Given this list of marker genes IL6, CNTF, CLU, ITGB4, SLC25A46, TNF, S100A8, GSTP1, MIOS, TREM2, EIF2B3, FPR2, GFAP, PHGDH, SOX10, B4GALT6, CCDC39, KRAS, SHH, ROR1, PRX, CDK6, ZNF488, ERBB2, TPPP, SIRT2, ZEB2, MAL, PLP1, AGER (NCBI Gene Id 177), RAF1, PRDM8, LRP1, FA2H, MAP2K1, PTEN, NAGLU, CERS6, IFNGR1, DICER1, ARHGEF10, MAPK3, SOX4, ILK, ASCL1, AKT1, MED12, VIM, ERBB3, MIR142, POU3F1, CNTN1, MAPT, EIF2B1, CNTN2, EIF2B5, HES5, CD9, APP (NCBI Gene Id 351), C5AR1, ANO1, WASF3, ADORA2A (NCBI Gene Id 135), ABCA2, IFNG, HRAS, PPP3R1, ID4, CNTNAP1, KCNJ10 (NCBI Gene Id 3766), PSEN1, MYOC, NRROS, IL1B, COL6A1, MAP2K2, SOX11, GRB2, MIR181C, NF1, POU3F2, ID2, TGFB1, NTRK3, C1QA, LAMB2, GPM6B, NCMAP, B4GALT5, TTBK1, PLEC, MIR26A1, NKX6-2 (NCBI Gene Id 84504), SH3TC2 (NCBI Gene Id 79628), LYN, SMO, NKX2-2, DRD1, SKI, OLIG1 (NCBI Gene Id 732056), TLR4, NR1D1, EIF2B4, DLL1, LAMC3, MXRA8, MYRF, MAG, MAPK1, S100A9, ADGRG6 (adhesion G protein-coupled receptor G6), GRN (NCBI Gene Id 2896), LGI4, CDK5, LDLR, NSUN5, NDRG1, NTRK2, DAG1, CSPG5, NCSTN, SOS1 (NCBI Gene Id 7838), MIR181B1, MDK, PALS1, AKT2, TLR2, SOD1, ERCC2, CERS5, EIF2B2, PICK1, LPAR1, PARD3, TENM4, TSPAN2, here is a description of the gene set: The process aimed at the progression of a glial cell over time, from initial commitment of the cell to a specific fate, to the fully functional differentiated cell. Human Gene Set: GOBP_GLIAL_CELL_DEVELOPMENT species: Homo sapiens